Given this list of marker genes AGRN, IFI44, GBP5, OAS1, ZBP1, TMEM268, IFIH1, SERPING1, IFIT1, CMTR1, ISG15, GALM, RHOC, IFI44L, HLA-DRA, MOV10, LIPA, TMEM62, PARP10, PARP12, PLSCR1, ZSWIM3, ETV7, SLFN13, IFIT2, GBP6, LPAR6, OAS3, CREB3L2, DDX60, WDR86, CLMP, TRIM5, GBP1, HERC6, TRIM14, SPATS2L (NCBI Gene Id 26010), XAF1, DHX58, SMTNL1, LY6E, SLFN5, IFIT5, SIGLEC1, PCK2, GBP3, IFI35, IFI6, ACO1, CYB561, LHFPL2, TIMM10, AIM2, MT2A, FCGR1A, OAS2, GBP4, PRPF31, PNPT1, RTP4, BATF2, LAP3 (leucine aminopeptidase 3), SAMD9L, GRAMD1B, KIAA1958, CD2AP, STOML1, RSAD2, P2RY14, IFIT3, BTN3A3, KLHDC7B, APOBEC3D, TRIM6, MX1, EXOC3L1, EPSTI1, CD274, ZNF680, TFEC, PARP14, TNIK, MDN1, CATSPER2, SCARB2, GCH1, LAMP3, GIMAP2, BST2, RNF144A, GIMAP1, MATCAP1, SAMHD1, RHPN1, BTN2A3P, TRIM22, TREX1, ZNF496, EVL, CARD17P, TLDC2, TRIB2, ZCCHC2, VAMP5, PPM1K, APOL3, EXOSC9, HERC5, FRMD3, EIF2AK2, USP18, SESTD1, CMAHP, PLPP6, ECHDC2, OASL (2'-5'-oligoadenylate synthetase like), IFITM3, SP140, CMPK2, here is a description of the gene set: species: Homo sapiens Human Gene Set: HOWARD_NEUTROPHIL_INACT_MONOV_INFLUENZA_A_INDONESIA_05_2005_H5N1_AGE_18_49YO_3DY_UP from publication Howard LM, Hoek KL, Goll JB, Samir P, Galassie A, Allos TM, Niu X, Gordy LE, Creech CB, Prasad N, Jensen TL, Hill H, Levy SE, Joyce S, Link AJ, Edwards KM (PMID 28099485) BACKGROUND: Vaccine development for influenza A/H5N1 is an important public health priority, but H5N1 vaccines are less immunogenic than seasonal influenza vaccines. Adjuvant System 03 (AS03) markedly enhances immune responses to H5N1 vaccine antigens, but the underlying molecular mechanisms are incompletely understood. OBJECTIVE: We compared the safety (primary endpoint), immunogenicity (secondary), gene expression (tertiary) and cytokine responses (exploratory) between AS03-adjuvanted and unadjuvanted inactivated split-virus H5N1 influenza vaccines. In a double-blinded clinical trial, we randomized twenty adults aged 18-49 to receive two doses of either AS03-adjuvanted (n = 10) or unadjuvanted (n = 10) H5N1 vaccine 28 days apart. We used a systems biology approach to characterize and correlate changes in serum cytokines, antibody titers, and gene expression levels in six immune cell types at 1, 3, 7, and 28 days after the first vaccination. RESULTS: Both vaccines were well-tolerated. Nine of 10 subjects in the adjuvanted group and 0/10 in the unadjuvanted group exhibited seroprotection (hemagglutination inhibition antibody titer > 1:40) at day 56. Within 24 hours of AS03-adjuvanted vaccination, increased serum levels of IL-6 and IP-10 were noted. Interferon signaling and antigen processing and presentation-related gene responses were induced in dendritic cells, monocytes, and neutrophils. Upregulation of MHC class II antigen presentation-related genes was seen in neutrophils. Three days after AS03-adjuvanted vaccine, upregulation of genes involved in cell cycle and division was detected in NK cells and correlated with serum levels of IP-10. Early upregulation of interferon signaling-related genes was also found to predict seroprotection 56 days after first vaccination. CONCLUSIONS: Using this cell-based systems approach, novel mechanisms of action for AS03-adjuvanted pandemic influenza vaccination were observed. TRIAL: ClinicalTrials.gov NCT01573312. Genes up-regulated in neutrophil 3d vs 0d in adults (18-49) after exposure to inactivated monovalent influenza A/Indonesia/05/2005 H5N1 split-virus vaccine, time point 3D, administered i.m.